The following is a description of a gene set: Mouse Gene Set: GOBP_SYNCYTIUM_FORMATION studied in species Mus musculus The formation of a syncytium, a mass of cytoplasm containing several nuclei enclosed within a single plasma membrane. Syncytia are normally derived from single cells that fuse or fail to complete cell division., and this is the list of marker genes: Ercc1, Mymk, Myod1, Dock5, Ins2, Camk1, Neo1, Gsk3b, Adam8, Syna, Scgb3a1, Cd9, Tanc1, Ntn3, Dock2, Nfatc2, Gdf15, Dock1, Mapk14, Ocstamp, Cd109, Ehd2, Adamts5, Il4ra, Sh3pxd2a, Cd53, Dyrk1b, Trem2, Igfn1 (NCBI Gene Id 226438), Il36g, Ccl8, Myog, Vash2, Wnt1, Ehd1, Adamts15, Synb, Cxcl12, Capn2, Plekho1, Izumo1, Adam9, Flt3l, Gcm1, Cdon, Cd81, Nfe2, Sbno2, Tnfsf14, Mymx, Adgrb1, Casp1, Flot1, Rapgef3, Cxcl9, Nphs1, Ripor2, Tcta, Cd44, Dcstamp (dendrocyte expressed seven transmembrane protein), Adgrb3, Stat1, Ccng1, Cacna1s, Cav3, Tyrobp, Cxcl10, Itgb1, Tmem182, Ptgfrn, Il4, Myh9, Cflar